Given this list of marker genes Slco4a1, Slc7a5, Slc7a8, Slc16a10, Slc17a4, Slc16a2, Slco1c1, Slco1a5, here is a description of the gene set: studied in species Mus musculus Enables the transfer of thyroid hormones from one side of a membrane to the other. Thyroid hormone are any of the compounds secreted by the thyroid gland, largely thyroxine and triiodothyronine. Mouse Gene Set: GOMF_THYROID_HORMONE_TRANSMEMBRANE_TRANSPORTER_ACTIVITY